Given this list of marker genes Carmil1, Dock2, Dnm2, Pycard, Kcnn4, Snx33, Appl2, Appl1, Stx1b, Mapkapk2, Mapkapk3, here is a description of the gene set: Mouse Gene Set: GOBP_MACROPINOCYTOSIS studied in species Mus musculus An endocytosis process that results in the uptake of liquid material by cells from their external environment by the 'ruffling' of the cell membrane to form heterogeneously sized intracellular vesicles called macropinosomes, which can be up to 5 micrometers in size.